The following is a description of a gene set: species: Mus musculus Any process that modulates the frequency, rate or extent of the chemical reactions and pathways resulting in the formation of cholesterol. Mouse Gene Set: GOBP_REGULATION_OF_CHOLESTEROL_BIOSYNTHETIC_PROCESS, and this is the list of marker genes: Por, Qki, Gpr146, Prkaca, Abcg4 (NCBI Gene Id 76887), Paqr3, Aqp8, Gnai1, Dhcr7, Sod1, Idi2, Apoe, Apob, Scp2, Mapk1, 3110082I17Rik, Insig1, Pex2, Cyp7a1, Lpcat3, Scap, Srebf2, Abcg1, Erlin2, Fdps, Srebf1, Erlin1, Npy1r, Sec14l2 (SEC14-like lipid binding 2), Mbtps2, Fgf1